Given this list of marker genes STK36, SPIN1, JPH4, IQSEC2, FAM219A, here is a description of the gene set: Genes predicted to be targets of miRBase v22 microRNA hsa-miR-6770-3p in miRDB v6.0 with MirTarget v4 prediction scores > 80 (high confidence targets). Human Gene Set: MIR6770_3P studied in species Homo sapiens from publication Chen Y, Wang X (PMID 31504780)